The following is a description of a gene set: Human Gene Set: MODULE_411 studied in species Homo sapiens Genes in the cancer module 411., and this is the list of marker genes: ACSL3, RNF133, MT1X, KCNJ1, MINK1, DMRT1, OSBPL10, HAGHL, CARF, NOD2, SLC38A2, PARP8, HRG, SLC7A5, SLC9A1, CFAP44, PTK7, ANKRD2, KRT35, S100A10, AIG1, FZD5, KATNAL2, ZNF608, S100A11, SLC9A6, RAPSN, EAF2, PSME4, RNASE2, ZFP36L1, PDE10A, TGM1, SLC10A1, XPR1, COMMD4, FUT1, CPA1, YJU2, LPCAT2, MLC1, PBX4, ASPSCR1, LMAN1L, BFSP2-AS1, OLFM4, PKD2L1, CRYBG1 (crystallin beta-gamma domain containing 1), SERPINB7, M1AP (NCBI Gene Id 130951), HYAL3, TSNAXIP1, ASAP2, IPP, CTAGE1, HOXB2, SLC16A2, PRKG2, MAK, B3GNT5, MAP7D3, SCPEP1, IQGAP1, ZBTB3, DLGAP3, SLC38A3, SRSF12, PCIF1, FABP3, TRMT1, CAMSAP2 (NCBI Gene Id 23271), PIGL, ALDH3A1, BTG3, SPATA31A7, TMEFF2, CEBPB, FBN3, CD226, CLN5